Given this list of marker genes PTGDS, SRY, NR5A1, ZFPM2, WNT4, DMRT1, AMH, SOX9, FGF9, DHH (NCBI Gene Id 791256), WT1, GATA4, FOXL2, here is a description of the gene set: In humans, primordial germ cells (PGCs) are specified about 2 weeks after fertilization, a time before gastrulation. PGCs are initially located extraembryonically and then migrate to colonize the gonadal ridges (genital ridges) of the embryo during the fifth week after fertilization. At this time, either ovaries and testes can originate from the gonadal ridges. That is, the cells of the gonadal ridges are initially bipotential and remain bipotential until about 42 days after conception, when transient expression of the SRY gene located on the Y chromosome in male embryos is initiated in some somatic cells of the gonadal primordium.<br>The transcription factors WT1, GATA4, ZFPM2 (FOG2), and the nuclear receptor NR5A1 (SF1) activate transcription of SRY. SRY and NR5A1 then activate transcription of SOX9, one of the master regulators of testis development and maintenance. Regulation of genes by SRY and then, when expression of SRY decreases, by SOX9 causes the specification of Sertoli cells that further organize formation of the testis by encasing the primordial germ cells in protocords, which then form fully developed testis cords.<br>SOX9 directly activates its own promoter to maintain SOX9 expression through development and into adulthood. SOX9 and GATA4 directly activate DMRT1 (inferred from mouse homologs), which maintains testis specification by maintaining expression of SOX9 and other testis-related genes. DMRT1 also acts to suppress ovarian specification by binding and repressing FOXL2 and WNT4 genes (inferred from mouse homologs). SOX9 directly activates FGF9 (inferred from mouse homologs), which acts via FGFR2 to maintain SOX9 expression, and PTGDS (inferred from mouse homologs), which converts Prostaglandin H2 to Prostaglandin D2, a critical hormone-like lipid that recruits supporting cells to Sertoli cells and acts indirectly to maintain SOX9 expression. SOX9, NR5A1, and GATA4 directly activate AMH (De Santa Barbara et al. 1998, and inferred from mouse homologs), an extracellular signaling molecule which causes regression of the Muellerian duct of the female reproductive system. SOX9 also directly activates many other genes, including DHH, an intercellular signaling molecule required for testis formation. part of: Developmental Biology Reactome Pathway: Transcriptional regulation of testis differentiation studied in species Homo sapiens